The following is a description of a gene set: electronically inferred by orthology from the curated human pathway This event has been computationally inferred from an event that has been demonstrated in another species.<p>The inference is based on the homology mapping from PANTHER. Briefly, reactions for which all involved PhysicalEntities (in input, output and catalyst) have a mapped orthologue/paralogue (for complexes at least 75% of components must have a mapping) are inferred to the other species. part of: Synthesis of bile acids and bile salts Reactome Pathway: Synthesis of bile acids and bile salts via 27-hydroxycholesterol studied in species Mus musculus, and this is the list of marker genes: Akr1c21, Ncoa1, Akr1d1, Akr1c6, Akr1c13, Cyp7a1, Akr1c14, Akr1c18, Nr1h4, Akr1c20, Cyp8b1